Given this list of marker genes AGO1, TNRC6A, MIR200C, TNRC6B, AGO4 (argonaute RISC component 4), MOV10, AGO2, TNRC6C, CDH11, AGO3, here is a description of the gene set: Regulation of CDH11 mRNA translation by microRNAs species: Homo sapiens Human Gene Set: REACTOME_REGULATION_OF_CDH11_MRNA_TRANSLATION_BY_MICRORNAS